Given this list of marker genes Itgb4, Etv2, Ahdc1, Eya1, Tal1, Inhba, Mmp14, Mesp2, Six2, Gja1, Gata6, Rtf1, Mmp2, Hnf1a, Leo1, Crb2, Smad1, Sox2, Col4a2, Foxf1, Smad3, Wnt3a, Dkk1, Itga8, Epha2, Kdm6b, Epb41l5, Prkaca, Tnrc6c, Dusp1, Myh9, Vtn, Gata4, Lhx1, Sox17, Wnt5a (wingless-type MMTV integration site family, member 5A), Chrd, Tlx2, Scx, Atoh8, Foxc1, Lama3, Kdm6a, Mmp15 (matrix metallopeptidase 15), Mmp8, Dusp5, Ext1, Itga3, Ctnnb1, Hnf1b, Fn1, Hand1, Map2k1, Tbx6, Pax2, Lamb3, Apela, Dusp4, Macf1, Col8a1, Smad2, Hoxa11, Htt, Fzd7, Nr4a3, Mixl1, Dab2, Cdc73, Itga2, Axin1, Gpi1, Bmpr2, Sfrp2, Exoc4, Itgb3, T, Brd3, Lef1, Mesp1, Col11a1, Bmp7, Col5a2, Ext2, Col12a1, Itga5, Bmp4, Nf2, Wls, Pofut2, Eomes, Col6a1 (NCBI Gene Id 12833), Itgav, Ets2, Txnrd1, Taf10, Foxa2, Paf1, Dusp2, Hsbp1, Srf, Wnt11, Tbx19, Ecsit, Twsg1, Acvr1, Snai1, Fgfr1, Nanog, Grb2, Kif16b (kinesin family member 16B), Pou5f1, Nr0b1, Macroh2a1, Nog, Wnt3, Foxc2, Nodal, Ctr9 (NCBI Gene Id 22083), Prkar1a, Bmpr1a, Itgb1, Elf5, Msgn1, Hmga2, Sox7 (NCBI Gene Id 20680), Arid1a, Mmp9, Col5a1, Setd2, Armc5, here is a description of the gene set: The formation of the ectoderm, mesoderm and endoderm during gastrulation. Mouse Gene Set: GOBP_FORMATION_OF_PRIMARY_GERM_LAYER studied in species Mus musculus